The following is a description of a gene set: Hepatocyte growth factor receptor signaling studied in species Homo sapiens Human Gene Set: WP_HEPATOCYTE_GROWTH_FACTOR_RECEPTOR_SIGNALING, and this is the list of marker genes: GRB2, MET, CRK, HRAS, MAP4K1, ITGB1 (NCBI Gene Id 3688), SRC, MAP2K1, RAPGEF1, PAK1, RASA1, SOS1, PTK2B, DOCK1, PTPN11, PXN, CRKL, MAPK8, PIK3CA, FOS, PTK2, RAF1, STAT3, RAP1A, MAP2K2, MAPK1, HGF, RAP1B, PTEN, JUN, ELK1, GAB1 (NCBI Gene Id 2549), MAPK3, ITGA1